The following is a description of a gene set: Characteristic neurologic anomaly resulting from degeneration of dopamine-generating cells in the substantia nigra, a region of the midbrain, characterized clinically by shaking, rigidity, slowness of movement and difficulty with walking and gait. Human Gene Set: HP_PARKINSONISM studied in species Homo sapiens Parkinsonism, and this is the list of marker genes: DNAJC13, TWNK, TSPOAP1, PDE10A, WDR45, UCHL1, TAF1, SCN9A, SNCA, GABRA1, VPS13C, SYNJ1, PDGFB, PSEN2, ATXN8OS, ATP7B, POLG, PTPA, GP1BB, SLC18A2, TMEM106B, GBA1, TBP, COMT, KCNN2, DNAJC5, CHCHD2, ADH1C, VCP, PTS, EIF4G1, PARK7, TNR, LYST (NCBI Gene Id 1130), MPV17, SCN2A, SLC39A14, RAB39B, ATN1, ATP1A3, CYP27A1, ATP13A2, KIF5A, SCN1A, CAT, AP5Z1, PRNP, PSAP, ARVCF, PRKRA, DNAJC6, ATP6AP2, EIF2AK2, PPP2R2B, AOPEP, PLA2G6, NOS3, SNCB, TRPM7, TBK1, PTRHD1, STUB1, GIGYF2, ATXN2, GRN, SCARB2, SPG11, ACBD6, AFG3L2, C19orf12, MYORG, VPS35, NR4A2, MPO, SCN1B, TH, CHMP2B, TOMM40, IMPDH2, PLAU, VPS13A, LRRK2, JPH3, GABRG2, TARDBP, PCBD1, NOTCH3, NAA60, APOE, FBXO7, ABCA7, CBS, SEC24C (SEC24 homolog C, COPII coat complex component), WARS2, COASY, PINK1, MAPT, MT-TT, HTRA2, TREM2, CP, COQ2, FTL, SLC20A2, HIRA (histone cell cycle regulator), SIGMAR1, JAM2, SORL1, PDGFRB, CLN3 (CLN3 lysosomal/endosomal transmembrane protein, battenin), GCH1, SLC30A10, UFD1, PSEN1, UQCRC1, TK2, JMJD1C, SQSTM1, C9orf72, UBTF, ATXN3, SNCAIP (synuclein alpha interacting protein), DNAJC12, XPR1, FMR1, MECP2, RREB1, PCDH19, SLC6A3, ALS2, PANK2, PRKN, CSF1R, DCTN1, APP, TMEM240, FUS, TBX1, CHCHD10, PRKAR1B, SPTLC1